Given this list of marker genes PRKN (NCBI Gene Id 8004, parkin RBR E3 ubiquitin protein ligase), NBR1, PINK1, FAF2, CISD1, TAX1BP1, HK1, MAP1LC3B, OPTN, MAP1LC3B2, TOMM70 (NCBI Gene Id 9868), MAP1LC3C, SQSTM1, CALCOCO2, CISD2, MAP1LC3A, FKBP8, here is a description of the gene set: PINK-Parkin-mediated autophagosome formation. Pathway ID: N01137. Pathway type: Reference. Pathway class: nt06464 Amyotrophic lateral sclerosis. Human Gene Set: KEGG_MEDICUS_REFERENCE_PINK_PARKIN_MEDIATED_AUTOPHAGOSOME_FORMATION species: Homo sapiens Pathway Definition from KEGG: PINK1 -> PRKN -> (CISD1,CISD2,FAF2,FKBP8,TOMM70,HK1) == (SQSTM1,OPTN,NDP52,TAX1BP1,NBR1) == LC3